Given this list of marker genes MAPK1, ADNP, EXOSC5, NKAP, GATA4, GNS, KMT2D, DZIP1, MTX2 (NCBI Gene Id 10651), CHST3, HADHB, STAT4, CTCF, LDLR, G6PC3, PCSK9 (proprotein convertase subtilisin/kexin type 9), COL1A2, ALDH18A1, PPP1R13L, SYT2 (NCBI Gene Id 6858), ALPK3, THSD1 (NCBI Gene Id 55901), LOX, GTF2IRD2, AKT3, KDM6A, COX7B, ACTC1, HAAO, METTL27, FBN1, NOTCH2, MYL2, GNPTAB, NF1, KLRC4, CITED2, UBE2A, FLNC, WBP4, FKBP6, GATA6, FBLN5, GTF2I, VPS37D, LTBP2, TWNK, LRPPRC, LMNA (NCBI Gene Id 7816), CLIC2, PYROXD1, FLNA, PLD1, SMAD3, ARSB, MLXIPL, HADHA, MCTP2, PRG4, RPL5, RIT1, KIF20A, BANF1, RPL3L, ZIC3, RFC2, FHOD3 (formin homology 2 domain containing 3), SGO1, FHL1, NCF1, DSE, GLB1, IL12A-AS1, HEXB, DNAJC30, ERAP1, RSPRY1, HEPHL1, IL6ST, COL5A2, FBN2, CHST14, TPM1, ADA2, GJA1, FKBP14, LMOD2, PRDM16, LIMK1, TNNI3, IDUA, ABCG5, DNMT3A, PPP1CB, IL10, DCHS1, IRX5, CBL, MYH6, BAG3, MAN2B1, ABCG8, PKD1, GBA1, POLG, NKX2-5, AGA, RPS6KA3, AHDC1, RAF1, VPS33A, CLIP2, SDHD, KLHL24, BAZ1B (bromodomain adjacent to zinc finger domain 1B), ZNF148, FAS, SPEG, COL5A1, COL1A1, GPR101, SOX5, MAP3K7, UBAC2 (NCBI Gene Id 94902), GTF2IRD1, IL23R, TNNT2, LZTR1, TLR4, CCR1, TMEM270, XYLT1, APOB, TLL1, HCCS, DOHH, ZMPSTE24, TBX20, B3GALT6, ADAMTSL2, DTNA, PEX2, ANKRD11, SMAD4, SKI, STX1A, GLA, TBX5, MYH7, HGD, SLC22A5, NOTCH1, MYPN, NDUFB11, C4A, TLR7, EIF4H, IFNGR1, AIP, PIK3R2, TBL2, BUD23, PDSS1, TGFB3, CRYAB (crystallin alpha B), HLA-B, IL12A, SMAD6, ELN, CCND2, LDLRAP1, TXNDC15, MEFV, XYLT2, ADAMTS17 (ADAM metallopeptidase with thrombospondin type 1 motif 17), LTBP3, ABCC6, ADAMTS10, here is a description of the gene set: Any functional anomaly of the mitral valve. Abnormal mitral valve physiology Human Gene Set: HP_ABNORMAL_MITRAL_VALVE_PHYSIOLOGY species: Homo sapiens